Given this list of marker genes Piwil2, Cdk6, D1Pas1, Chek2, Piwil1, Nfatc1, Nanos2, Ube2b, Xrcc5, Spo11, Dek, Sycp2 (synaptonemal complex protein 2), Lin37, Nfib (nuclear factor I/B), Nfia, Mei1, Nfix, Mir489, Fancb, Trex1, Cdc20, Nfe2l1, Ttk, Terf1, Mlh1, Topaz1, Haspin, Fance, Paupar, here is a description of the gene set: One of the distinct periods or stages into which the cell cycle is divided. Each phase is characterized by the occurrence of specific biochemical and morphological events. species: Mus musculus Mouse Gene Set: GOBP_CELL_CYCLE_PHASE